The following is a description of a gene set: During acute viral infections, naïve CD8+ T cells differentiate into effector CD8+ T cells and, after viral control, into memory CD8+ T cells. Memory CD8+ T cells are highly functional, proliferate rapidly upon reinfection and persist long-term without antigen. In contrast, during chronic infections, CD8+ T cells become “exhausted” and have poor effector function, express multiple inhibitory receptors, possess low proliferative capacity, and cannot persist without antigen. To compare the development of functional memory T cells with poorly functional exhausted T cells, we generated longitudinal transcriptional profiles for each. Human Gene Set: GSE41867_DAY8_EFFECTOR_VS_DAY30_EXHAUSTED_CD8_TCELL_LCMV_CLONE13_DN from publication Doering TA, Crawford A, Angelosanto JM, Paley MA, Ziegler CG, Wherry EJ (PMID 23159438) species: Homo sapiens Genes down-regulated in CD8 T cells during chronic infection with LCMV-Clone 13: effectors at day 8 versus exhausted at day 30., and this is the list of marker genes: MCM9, NAT1, TANK, SNX30, ACACA, TTC33, CSF1, TRAF3IP3, CNST, BLOC1S6, PURB, RFX7, TANC2, PCMTD1, GLIPR1 (NCBI Gene Id 11010), SPAG9, SWAP70 (switching B cell complex subunit SWAP70), AIG1, TAMALIN, GNA12, INIP, SH2D3C, OSGEP, SYS1, RPL26, AP4S1, BIN1, XRCC1, AFG2B, CD180, USP14, RNF145, FHIT, CORO1A, PUM1, HACE1, CHST7, PARP1, NUBP1, HERC2, EYA1, RMI2, PPDPF, NUDT19, CTSA, RFLNA, KCTD1, IFT122, RTCB, TAF10, UCKL1, PDCD1LG2, MRPL41, ZDHHC13, RAPGEF4, CABLES1, FANCL, PIERCE2, TMEM53, ANKRD44, MFSD14B, FGF13, ADD3, SH3BP5, SEMA4D, SDHAF2, LCLAT1, CNOT2, PTGS1, NCF2, TESK1, DENND2D, AHR, FAM167A, TAGAP, RFESD, MBD4, LRWD1, S1PR3, ALDH16A1, STK17B, GABPB2, IL1R2, TUBG2, MAP3K20, JAK2, RBMS1 (NCBI Gene Id 5937), ABHD2, GLYCTK, CHSY1 (NCBI Gene Id 22856), VPS37B, AP1S3, GRM1, NOP53 (NCBI Gene Id 94457), TMEM108, CTDP1, TCF12, RAD17 (NCBI Gene Id 5884), ANKRA2, ZBED4, EED, COTL1, C2orf76, CISD2, RPL36, HIVEP3 (NCBI Gene Id 86368), TBCE, COMMD6 (NCBI Gene Id 170622), VASP, GADD45A, PLCD3, MICAL1, IFI27, ZNF521, INPP5D, SRF, LAMP1, PIK3IP1, MYBL1, CPSF3, HPGDS, ERP44, UBLCP1, PPTC7, PACRGL, LRRC2, MYH9, SESN1, MLLT10, DZIP3, HDAC11, PREX1, MKNK2, ARMCX4, C2CD3, PPIL2 (peptidylprolyl isomerase like 2), PTP4A3, EIF3K, CSF2RA, CSTF2T, LRRK1, TMEM17, SFT2D1, HSPBAP1, KCTD14, MAP4K1 (NCBI Gene Id 11184), DFFB, ANKRD10, CEP63, KHDRBS1, FCRL1, MIDEAS, NCOA3, GRIPAP1, ARID5B, TBC1D4, ZBTB25, STAMBPL1, FBXW2, SUMF1, PARM1, ASNSD1, WDR44, NTPCR, LPCAT1, IFI30, GPSM3, MYL11, RETREG1, GAMT, HRH2, STMP1, POLR3C, TAF15, PDGFA, DSC2, PQBP1, LTBP3, AFP (alpha fetoprotein), MAPRE2, HSCB, CDK19, SLC30A4, SLC35F5 (solute carrier family 35 member F5), DDX4, VAMP4, MACO1, USP2, ENPP6, TFEB, ANAPC13, SNX10, STARD4, INTS9, EFL1, UNC13D, CAPZB, DNASE1L3, CCM2, MGA